The following is a description of a gene set: An anomaly of the little toe. Human Gene Set: HP_ABNORMAL_FIFTH_TOE_MORPHOLOGY studied in species Homo sapiens Abnormal fifth toe morphology, and this is the list of marker genes: TMEM216, TMEM107, HOXD13, ZNF141, INPP5E, NEK1, GLI3, DYNC2I2, RPGRIP1, CEP290, TCTN1 (NCBI Gene Id 79600), BBS1, OTUD5, RNF6, CIBAR1, C2CD3, CSPP1, DLEC1, DYNLT2B, MKS1, PRKACB, WWOX, CHSY1, SMARCA4, TMEM237, ARL6, HEPHL1, LBR, PLAA, ALG3, BBS12 (Bardet-Biedl syndrome 12), FREM1, NOG, TRMT10A, DHCR7, PDE6D, KCNN3, LZTFL1, DYNC2H1, RAB34, MAX, DYNC2I1, CCDC28B, WDR19, SC5D, SUFU, KCNJ5, IFT80, EVC2, CC2D2A, SMO, TMEM67, BBS9, KIAA0825 (NCBI Gene Id 401202), TGFBR2, NPHP3, OFD1, TCTN3, TMEM231, IFT27, PPP1R15B, KCNJ2, MAP3K20, MKKS, CD96, BMP4, CEP120, IQCE, PIGH, IFT172, EVC, B9D2, KIAA0753, B9D1, TTC21B, RAB3GAP2, BBS2, SCNM1, TCTN2, ARID1B, IFT140, SMOC1, SALL1, DYNC2LI1, KIF7, EXTL3, FRA10AC1, RPGRIP1L, SETD5, CKAP2L, IFT74, TXNDC15, DDX59